The following is a description of a gene set: Reactome Pathway: Malate-aspartate shuttle studied in species Mus musculus This event has been computationally inferred from an event that has been demonstrated in another species.<p>The inference is based on the homology mapping from PANTHER. Briefly, reactions for which all involved PhysicalEntities (in input, output and catalyst) have a mapped orthologue/paralogue (for complexes at least 75% of components must have a mapping) are inferred to the other species. electronically inferred by orthology from the curated human pathway part of: Respiratory electron transport, and this is the list of marker genes: Mdh2, Got2, Got1, Slc25a18, Slc25a22, Slc25a13, Slc25a11